Given this list of marker genes PSMA8, PSMB10, PSMB8, PSME4, PSMB9, here is a description of the gene set: Human Gene Set: GOCC_SPERMATOPROTEASOME_COMPLEX A proteasome specifically found in mammalian testis. Contains the proteasome activator PA200 in the regulatory particle, and beta1i, beta2i, beta5i and/or alpha4s in the core (20S) subunit. Beta1i, beta2i and beta5i are inducible catalytic subunits, closely related to beta1, beta2 and beta5. Alpha4s is a sperm-specific 20S subunit, but unlike other alternative 20S subunits alpha4s lies in the outer alpha-ring and lacks catalytic activity. studied in species Homo sapiens